The following is a description of a gene set: Mouse Gene Set: GOCC_CELL_LEADING_EDGE studied in species Mus musculus The area of a motile cell closest to the direction of movement., and this is the list of marker genes: Kank1, Dctn1, Ptprj, Tiam1, Hax1, Cfl1, Grin2a, Bspry, Dusp22, Baiap2 (NCBI Gene Id 97767), Gabra6, Cdc37, Coro1b, Iqgap1, Syne2, Stx2, Ssh1, Palld, Tmem87a, Tesc, Ablim1, Eef1a1, Plce1, Shtn1, Fat1, Dpp4, Tiam2, Angptl3, Ldb1, Pip5k1a, Hcn2, Sh3yl1, Arhgap1, Psd4, Jmy, Nf2, Kcnc1, Dmd, Lmo4, Brk1, Klhl2, Cntnap2, Plekho1, Acta1, Kif18a, Ssx2ip, Ripor2, Stx3, Atp2b1, Bcas3, C2cd5, Pld2, Atp7a, Rigi, Casp8, Myo1g, Wmp, Clasp2, Adgrv1, Rasa1, Cd2ap, Arhgap44 (NCBI Gene Id 216831), Reg1, Rab22a, Rab3ip, Synj2, Pla2g4f, Shisa6, Arap3, Mcf2l, Mtmr14, Apbb1, Arhgef6, Kcnj11, Cdc42, Adgre5, Akap5, Avil, Asap3, Map2, Fam89b, Ctnnd1, Gbf1, Phldb2, Inpp5j, Ppp1r9a, Myo5a, Wasl, Scrib, Cdc42bpg, Oprd1, Pdxp, Tubb3, Duoxa1, Rinl, Trpc2, Macf1, Pip5k1c, Sh3bp1, Fap, Plek2, Nme1, Snx1, Ptprz1, Dag1 (NCBI Gene Id 13138), Dysf, Dbn1, Knstrn, Tacr3, Coro1c, Bloc1s6, Actc1, Itgav, Epb41l3, Limk1, Pdlim4, Adam17, Plekhg5, Plek, Wasf3 (WASP family, member 3), Rdx, Arf6, Adora2a, Actr3, Itga8, Pafah1b1, Ablim3, Fermt1, Abitram, Tpm1, Rapgef3, Src, Gabrg1, Rnh1, Tmod3, Carmil2, Vasp, Itgb3, Lcp1, Arfip2, Wwc1, Cyth2, Arf4, Mkln1, Hpca, Nherf1, Phpt1, Mefv, Wipf1, Itgb5, Chrna7, Gabrg3, Abi1, Dnm2, Gm28729, Arhgap45 (Rho GTPase activating protein 45), Mylk, Nradd, Ddn (NCBI Gene Id 328602), Eps8l2, Cdh2, Cttn (cortactin), Inppl1, Slc9a5, Caprin1, Robo2, Sh3rf1, Twf2, Cdkl5, Exoc8 (NCBI Gene Id 97490), Them4, Swap70, Ptprm, Scimp, Podxl, Pkhd1l1, Psd2, Kcnh1, Flot2, Ank1, Ddx3x, Pik3ca, Fermt2, Igf2bp1, Ppp1r9b, Srcin1, Kcnn4, Ctnnb1 (NCBI Gene Id 12387), Gabre, Tescl (NCBI Gene Id 69301), Spry4, Arpc3, Mapk8ip3, Hcn1, Tln2, Clcn2, Plcg1, Duox2, Sh2d3c, Spry2, Atp6ap2, Ctnna2, Phactr4, Bmx, Tesk1, Gnas, P4hb, Tlr4, Slc1a2, Ndel1, Kitl, Unc5c, Stxbp2, Slk, Amotl1, Myo1d, Git1, Myh9, Jcad, Enah, Pld1, Appl2, D1Pas1, Hdac6, Insr, Cyfip1, Capzb, Srgap2, Psd3, Snap25, Gas7, Ksr1, Rasgrp2, Inpp5e, Shisa9, Itgb4, Cyth3, Psd, Slc39a6, Amph, Capg, Kptn, Aif1, Iqgap2, Nme2, Ptpn13, Snx5, Sptbn1, Arpc2, Dynlt1a, Epb41l5, Mtss2, Trpv1, Prkcz, Fgd2, Dgkz, Kcnc4 (NCBI Gene Id 99738), S100b, Fgr, Rab13, Fer, Acta2, Carmil3, Arf1, Abl2, Rab34, Plxnd1, Snx2, Trpv2, Coro1a, Cadm4, Kcna2, Pdgfrb, Pear1, Myo1a, Cit, Gabarapl1, Dlc1, Rac3, Stx4a, Gper1, Fscn3, Lamp5, Nckap1, Cacng8, Trpm7, Pde9a, Plekhh2, Myh10, Klhl41, Trpv4, Cdh1, S100a6, Rac1, Atp2b2, Kcnc2, Shisa8, Evl, Gria1, Dagla, Plekha1, Flot1, Fgd4, Pkd2, Frmd4b, Inpp5k, Sh2b2, Dynlt1c, Wasf1, Rock1, Apc, Dpysl3, Myadm, Arhgap31 (NCBI Gene Id 80655), Spef1 (NCBI Gene Id 70997), Prkci, Fscn1, Fignl2, Raph1, Nedd9, Ldb2, Abca7, Itga5, Parva, Tln1, Robo1, Abi3, Pxn, Arhgef2, Arpin, Slc12a5, Rps3, Thy1, Wls (wntless WNT ligand secretion mediator), Mapt, Myo9b, Ush2a, Duoxa2, Vezt, Samsn1, Arhgef7, Ptk2, Scyl3, Spata13, Actn1, Kdf1, Acap2, Gabra1, Ezr, Pacsin1, Rufy3 (RUN and FYVE domain containing 3), Pdlim7, Diaph1, Gdpd2, Hip1r, Fgd5, Gabra5, Apbb1ip, Arpc5, Myo6, Ctnna1, Mtmr6, Twf1, Ripor1, Aak1, Actb, Cd44, Sh2b1 (SH2B adaptor protein 1), Rab5a, Erbb2, Palm, Cxcr4, Ptk2b, Parvb, Dst, Plcg2, Notch1, Eps8, Ngfr, Ston1, Pstpip1, Ajuba, Itsn1, Exoc4, Cttnbp2nl, Pkn2 (NCBI Gene Id 99668), Kcnb1, Arhgap18, Ctnna3, Stmn2, Gsn, Piezo1, Cdc42bpa, App, Clrn2, Anxa2, Actr2, Atp6v1b2, Myo10, Grin1, Gabra3 (gamma-aminobutyric acid type A receptor subunit alpha 3), Appl1, Eps8l1, Fgd1, Tnfrsf12a, Amot, Cdk5, Clip1, Washc1, Cdc42bpb, Sorbs2, Gabra4, Snx9, Pabpc1, Als2, Duox1, Cdk6, S100a11-ps, Rac2, Sgce, Antxr1, Ilk, Kcnc3, Carmil1, Adora1, Dynlt1b, Ywhaz, Shisa7, Cspg4, Fam107a, Mtm1, Oprm1, Gabbr1, Atn1, Cib1, Egfr, S100a11, Vim, Epha2, Nrbp1, Gabrg2, Eps8l3, Mpp2, Dock8, Akt2, Gria2, Mcoln3, Abl1, Vil1, Gabra2, Tubg1, Ccdc88a, Dpp9, Pak1, Pacsin2, Layn, Itgb1bp1, Sh3bgrl3, Atf4 (NCBI Gene Id 11911), Ptk6, Lima1 (LIM domain and actin binding 1), Aif1l (NCBI Gene Id 98846), Unc5a, Pecam1, Pdpn, Dbnl, Mtmr9 (NCBI Gene Id 210376), Ptprk, Clrn1 (clarin 1), Cacna1d, Rhoa, Itgb1, Abi3bp, Actg2, Tsc1, Tirap, Abi2, Myo1c, Bcar1, Cobl, Dynlt1f, Apc2, Sntg1, Wasf2